Given this list of marker genes UBTFL6, RRN3P1 (RRN3 pseudogene 1), TAF1C, TAF1, UBTF, UBTFL1, RRN3, RRN3P2, here is a description of the gene set: Human Gene Set: GOMF_RNA_POLYMERASE_I_GENERAL_TRANSCRIPTION_INITIATION_FACTOR_ACTIVITY species: Homo sapiens A general transcription initiation factor activity that contributes to transcription start site selection and transcription initiation of genes transcribed by RNA polymerase I. Factors required for RNA polymerase I transcription initiation include upstream activation factor (UAF), core factor (CF), TATA binding protein (TBP) and RRN3. In all species characterized, RNA polymerase I transcribes a large polycistronic transcript that is processed into several mature rRNAs (3 or 4 depending on the species), including the large subunit rRNA (28S in humans), the small subunit rRNA (18S in humans), as well as one or two additional smaller rRNAs (the 5.8S rRNA in humans). In most species, this large rRNA transcript is the sole product of RNA polymerase I. However there are rare exceptions, such as Trypanosoma brucei, where RNA polymerase I also transcribes certain mRNAs.